The following is a description of a gene set: studied in species Mus musculus Reactome Pathway: SLC-mediated transmembrane transport part of: Transport of small molecules electronically inferred by orthology from the curated human pathway This event has been computationally inferred from an event that has been demonstrated in another species.<p>The inference is based on the homology mapping from PANTHER. Briefly, reactions for which all involved PhysicalEntities (in input, output and catalyst) have a mapped orthologue/paralogue (for complexes at least 75% of components must have a mapping) are inferred to the other species., and this is the list of marker genes: Slc25a11, Slc2a4, Slc2a8 (solute carrier family 2, (facilitated glucose transporter), member 8), Slco4c1, Slc2a6, Slc5a8, Slc39a14, Slc9a1, Slc39a2, Slc9a6, Pdzd11, Slc17a8, Slc15a1, Slc22a16, Slc7a7, Slc29a2, Slc1a7, Slc11a1, Slc6a3, Slc4a2, Slc15a3, Slc5a2, Slc22a6, Slc6a1, Slc11a2, Slc26a2 (solute carrier family 26 (sulfate transporter), member 2), Slc6a19, Slc22a3, Slc41a2, Slc17a1, Slc30a5, Lcn12, Slc41a1, Slc12a5, Slc35d2, Slc25a5, Slc26a1, Slc24a3, Slc26a6 (NCBI Gene Id 171429), Slc39a6, Slc14a2, Slc4a9, Slc12a4, Slc47a1, Slc29a3, Slc4a10, Slco1a4, Slc6a7, Avp, Slc28a1, Slc24a5, Slc25a10, Slc7a6, Slc22a18 (NCBI Gene Id 18400), Slc5a7, Slc1a4, Slco1c1, Slc6a9, Slc25a22, Slc7a9, Slc8b1, Slc36a2, Slc38a2, Fgf21 (fibroblast growth factor 21), Slc22a1, Slc27a1, Slc5a3, Lcn9, Slc39a4, Slc44a4, Slc24a2, Slc22a2, Slc5a4a, Slc4a8, Slc17a7, Slc13a1, Slc2a13, Slc20a2 (solute carrier family 20, member 2), Slc26a11, Slc16a3, Slc3a1 (NCBI Gene Id 20532), Slc35c1, Slc3a2, Ctns (NCBI Gene Id 83429), Slc26a7, Ahcyl2, Slc27a6, Slc44a2, Slc22a5, Apod, Slc22a12, Slc7a8, Mfsd4b4, Slc16a10, Slc13a4, Slc7a3, Slc35d1, Slc22a8, Slc5a9, Slc26a9, Slc2a12, Slc4a1, Calm1, Slc35b2, Slc36a4, Slc30a10, Slc24a1, Slc44a3, Slc6a2, Slc26a4 (NCBI Gene Id 23985), Bsg, Slc25a18, Slc4a4, Slc39a7, Slc5a6, Slc2a1, Slc25a4, Slc12a3, Slc13a2, Slc16a8, Slc6a13, Slc50a1, Slc9a5, Slc12a2, Slc30a8, Slc7a10, Slc1a6, Slc38a3, Slc13a3